Given this list of marker genes Dnase1, Stradb, Smarca2, Bfar, Gzma, Ppbp, here is a description of the gene set: Mouse Gene Set: KIM_GLIS2_TARGETS_DN species: Mus musculus Partial list of genes down-regulated in the kidney of GLIS2 knockout mice compared to the wild type. To obtain insight into the physiological functions of the Krüppel-like zinc finger protein Gli-similar 2 (Glis2), mice deficient in Glis2 expression were generated. Glis2 mutant (Glis2(mut)) mice exhibit significantly shorter life spans than do littermate wild-type (WT) mice due to the development of progressive chronic kidney disease with features resembling nephronophthisis. Glis2(mut) mice develop severe renal atrophy involving increased cell death and basement membrane thickening in the proximal convoluted tubules. This development is accompanied by infiltration of lymphocytic inflammatory cells and interstitial/glomerular fibrosis. The severity of the fibrosis, inflammatory infiltrates, and glomerular and tubular changes progresses with age. Blood urea nitrogen and creatinine increase, and Glis2(mut) mice develop proteinuria and ultimately die prematurely of renal failure. A comparison of the gene expression profiles of kidneys from 25-day-old/60-day-old WT and Glis2(mut) mice by microarray analysis showed increased expressions of many genes involved in immune responses/inflammation and fibrosis/tissue remodeling in kidneys of Glis2(mut) mice, including several cytokines and adhesion and extracellular matrix proteins. Our data demonstrate that a deficiency in Glis2 expression leads to tubular atrophy and progressive fibrosis, similar to nephronophthisis, that ultimately results in renal failure. Our study indicates that Glis2 plays a critical role in the maintenance of normal kidney architecture and functions. from publication Kim YS, Kang HS, Herbert R, Beak JY, Collins JB, Grissom SF, Jetten AM (PMID 18227149)